Given this list of marker genes RORB, NRP1 (NCBI Gene Id 8829), NOTCH1, ATP2B4, RP1, MERTK, CLDN19, RBP4, LAMA1, RHOJ, NRL, HCN1, PDGFRB, NFIA, FOXN4 (NCBI Gene Id 121643), PTF1A, XRN2, JMJD6, ACVRL1, BAX, SDK1, ROM1, FZD4, HES1, HIPK2 (NCBI Gene Id 653052), LHX2, SLC17A8, MFSD8, BMPR2, THY1, NFIB, ARHGEF15, HIF1A, GDF11, ARL6, CNTF, SLC4A5, MFSD2A, BSG, CELF4, SOX9, CLCN2, PTPRM, USH1C, DRAM2, PROM1, SLC17A7, TULP1, ACHE, RD3, NECTIN1, LAMB2, NEUROD4, ARSG, THRB, LPCAT1, DCX, TFAP2A, ATOH7, TGIF1, SOX8, CLN8, TBC1D32, SMARCD3, DLL1, VAX2, PDE6B, MED1, DLL4, PSEN1, ACVR2B (activin A receptor type 2B), TGIF2, LARGE1, GNAT1, SAMD7, SERPINF1, TTLL5, FAT3, ZHX2, SDK2, POU4F2, TCIRG1, BBS10, PDGFRA, SKI, CRX, GRN, MAN2A1, NR2E3, GNB1 (G protein subunit beta 1), PER2, COL4A1, GPM6A (glycoprotein M6A), DSCAM, GNAT2, TTC8, BMPR1B, DTNBP1, CRB1 (NCBI Gene Id 6107), CABP4, GRM6, TFAP2B, BBS4, DIO3, PRDM1 (NCBI Gene Id 639), PROX1, VSTM4 (V-set and transmembrane domain containing 4), MYH10, NTRK2, HPCA, PRPH2, RS1, MEGF11, PAX4 (paired box 4), RDH13, SLC38A8, HIPK1, DLX2 (distal-less homeobox 2), DLX1, NEUROD1, ELP6, TSPAN12, USP45, CASP2 (caspase 2), CLIC4, SIX3, VSX2, PDE6A, ZNF513, SMARCA4, RPE65, NECTIN3, PAX6, RHO, VSX1, LRP5, FJX1, SCAPER, CHD7, CDON (NCBI Gene Id 50937), TGFB2, LAMC3, ACTL6A, IRX5, NPHP1, TUB, PAX2, IHH, CALB1, FOS, PFDN5, CLDN3, AHI1, LHX1, NR2E1, NAGLU, RPGRIP1L, RRM1, NPHP4, MDM1, TGFB1, ATP8A2, SAMD11, RP1L1, RAB11FIP4, SLC1A1, RPL24, CYP1B1, RPGRIP1, AGTPBP1, OPN4, NDP, IMPG2 (NCBI Gene Id 51443), CRB2, STAT3, BARHL2, TMEM135, MFRP, BBS1, PDE6C, here is a description of the gene set: Human Gene Set: GOBP_RETINA_DEVELOPMENT_IN_CAMERA_TYPE_EYE studied in species Homo sapiens The process whose specific outcome is the progression of the retina over time, from its formation to the mature structure. The retina is the innermost layer or coating at the back of the eyeball, which is sensitive to light and in which the optic nerve terminates.